The following is a description of a gene set: studied in species Mus musculus Binding to tropomyosin, a protein associated with actin filaments both in cytoplasm and, in association with troponin, in the thin filament of striated muscle. Mouse Gene Set: GOMF_TROPOMYOSIN_BINDING, and this is the list of marker genes: Lmod2, Tmod2, Tmod3, Nebl, Lmod1, Lmod3, Tnnt1, Smtnl1, Tmod4 (tropomodulin 4), Tmod1, Pycard, Tnnt3 (troponin T3, skeletal, fast), S100a6, Tnnt2